Given this list of marker genes ADA, GRP, RGS2, ABHD6, RGS6, VPS35 (VPS35 retromer complex component), GPR158, PDC, UBQLN2, ADRB2, GNG4, SAG, GRK3 (G protein-coupled receptor kinase 3), RAMP2, ZDHHC3, SLC39A14, PDE6H, PDE3B, ARRB2, PKD2, ACP3, GPR27, SLC24A4, RACK1, GIPR, MET, STMN1, CAMK2A, GIT1, FGF8, GRM5, CCL5, NMT2, F2, GUCY2D, ADM, PRMT5, TREM2, SLIT2, ALK, CAMKMT, TMOD2, GRK7, RGS13, RGS12, PPP3CA, KLK14, MIR133A1, GSK3A, ARRB1, RGS18, GRK4, RGS10, PHB1, PDE2A, KCTD12, ZDHHC7, PDE10A, DTNBP1, PPP1R9B, CALCA (calcitonin related polypeptide alpha), HOMER2, KCTD16, DRD3, ATP2B4, SNCA, PDE4B (phosphodiesterase 4B), ADCYAP1, ROBO1, RIC8B, APP, PRKCA, MRAP2, SH2B3, PTGDR2, TUB, PLEK, CHGA, USP33, RGS20, NRXN1, GNG7 (NCBI Gene Id 90274), PLD2, PADI2, CRTC3, DYNLT1, C3, CXCL8, MIR30E, EDN1, PDE3A, APLP1, BICD1, GAS2L2, PHF24, ROCK2, MIR101-1, INPP5A, RGS5, FRMPD1, GNAI2, MIR1-1, NOS1, BECN2, YWHAB, KCTD8, ULK4, GPRASP1, NECAB2, TULP3, ARR3, GTF2H2 (NCBI Gene Id 2966), GRK1, PDCL, GPER1, SLIT3, RAMP3, MGLL, APELA, RNF113A, USP20, GRK6, APLNR, NMT1, AIPL1, ROCK1, CNTN2, APLN, HIF1A, GUCY2F, RPH3AL, GRK5, MGRN1, MIR20A, ADRB3, DRD2, GIT2, MRAP, LRRK2, GNAT1, GRK2, RGS9, SYP, RAMP1, RGS3, PDE4A, RGS14, PDE4D, KLK6, POMC (proopiomelanocortin), ARRDC3, RPGRIP1L, CRY1, RGS4, CAV2, PLCB1, RGS8, PDE6G, PALM, RGS7, KLK5, RGS11, RGS16, ITGB3 (NCBI Gene Id 3690), here is a description of the gene set: Human Gene Set: GOBP_REGULATION_OF_G_PROTEIN_COUPLED_RECEPTOR_SIGNALING_PATHWAY studied in species Homo sapiens Any process that modulates the frequency, rate or extent of G protein-coupled receptor signaling pathway.